Given this list of marker genes KIR2DL4, CD160, KLRC2, KLRC4-KLRK1, KLRK1, LILRB1, KLRC1, KLRD1, here is a description of the gene set: Human Gene Set: GOMF_MHC_CLASS_IB_RECEPTOR_ACTIVITY studied in species Homo sapiens Combining with an MHC class Ib protein complex and transmitting the signal from one side of the membrane to the other to initiate a change in cell activity. Class Ib here refers to non-classical class I molecules, such as those of the CD1 or HLA-E gene families.